Given this list of marker genes SMARCC1, MYEF2, METTL2A, DNLZ, NFKB2, MDN1, ROR2, CTBS, SOX17, SETD4, ATG9B, OSR2, NHP2, C18orf54, HSPBAP1 (HSPB1 associated protein 1), TRIM9, PMF1, LRP8, HIRA (histone cell cycle regulator), YBX3, NSUN5, NME1, DHX58, SNRPG, SNX24, SFSWAP, MYC, DDX49, NELFA, RAD23A, PDXK, NOL8, VARS1, STOML1 (NCBI Gene Id 9399), CCDC86, ASCL2, GAR1, ZBTB21, QTRT2, EPHB2, ATRIP, RPL31, FZD6, MVK, NFS1, OGFOD1, THOP1, PTHLH, MUS81, PMM1, RANGRF, LRMDA, TP53RK, GTSE1, D2HGDH, SMPD4, RGS12, GNPNAT1, SRGAP2, BOD1L1, HAGHL, ZNF800, LMNB2 (NCBI Gene Id 84823), KAT2A, RNASEH2C, FARSB, CDK4, DENND6B, SLC1A3, RAI14, ARX, ERCC1, DDAH1 (NCBI Gene Id 23576), SHPRH, SIDT1, ANKRD39, ERCC4, FBL, TRDN, NEUROG3, TFPT, MUTYH, RCC2, RASSF4, PCBP4, ACER2, GIPC1, POLE, QTRT1, FADS2, EMC8, BMP7, TGIF2, SLC1A4, FADS3, MCM3, TRMT61A, TFIP11, SLCO3A1, RABEP2, NTMT1, SNRPF, KNOP1, PABPC4, LANCL2, METTL1, TXNRD2, SLC35B2, ZBED3, GINS2, RNASEH2A, CDC42BPA, AAAS, RPS6KA6, ATMIN, METTL13, NBEAL2, RPS13, CABCOCO1, MYBBP1A, DRG2, MRPL38, LFNG, NASP, PHGDH, IFFO2, GTPBP3, NCEH1, CCDC163, ZSWIM3, HOMER1, ALKBH2, ZNF213, GET1, TELO2, SOX4, DPH2, YAE1, SIGMAR1, TIMELESS, ZMYND19, DUS3L, PPP1R14B, BIVM, ZBTB48, GRWD1, YJU2, CINP, TP53, GEMIN5, TMEM141, MCM7, DYNC2I2, TUBB2A, HOXA9, TTC27, TMPO, NOP56, POLR1A, SEMA3B, GTPBP6, PTOV1, SAPCD2, OGG1, FHOD1, WDR62, TMEM186, TRIB1, BCL11B, EXOSC1, BID, CENPP, BCL11A, AAR2, SMYD5, NRF1, DTYMK, GORASP1 (NCBI Gene Id 64689), RRP9, NOLC1, HES6, MBD3, GAS8, BUB1B, PRSS41, CREBBP, CITED1, POFUT1, VARS2, USP20, VEZT, C17orf49, SIVA1, WDR54, SHMT1, LHPP, SKA1, POMT1, AQR, TK1, CCT4, RNF157, SHMT2, ZNF444, CAD, SRD5A3, MFSD13A, TNFRSF12A, MAP4K4 (mitogen-activated protein kinase kinase kinase kinase 4), ADAT1, PPAN, SLC29A2, SRM, LDB1 (LIM domain binding 1), TXNRD3, ARHGEF12, AXIN2, MED22, MAPK7, RAD54L, ZFP2, SYTL1, CCT7, WDR4, TRMT9B, here is a description of the gene set: from publication Sansom OJ, Meniel VS, Muncan V, Phesse TJ, Wilkins JA, Reed KR, Vass JK, Athineos D, Clevers H, Clarke AR (PMID 17377531) Human Gene Set: SANSOM_APC_TARGETS_REQUIRE_MYC studied in species Mus musculus The APC gene encodes the adenomatous polyposis coli tumour suppressor protein, germline mutation of which characterizes familial adenomatous polyposis (FAP), an autosomal intestinal cancer syndrome. Inactivation of APC is also recognized as the key early event in the development of sporadic colorectal cancers, and its loss results in constitutive activity of the beta-catenin-Tcf4 transcription complex. The proto-oncogene c-MYC has been identified as a target of the Wnt pathway in colorectal cancer cells in vitro, in normal crypts in vivo and in intestinal epithelial cells acutely transformed on in vivo deletion of the APC gene; however, the significance of this is unclear. Therefore, to elucidate the role Myc has in the intestine after Apc loss, we have simultaneously deleted both Apc and Myc in the adult murine small intestine. Here we show that loss of Myc rescued the phenotypes of perturbed differentiation, migration, proliferation and apoptosis, which occur on deletion of Apc. Remarkably, this rescue occurred in the presence of high levels of nuclear beta-catenin. Array analysis revealed that Myc is required for the majority of Wnt target gene activation following Apc loss. These data establish Myc as the critical mediator of the early stages of neoplasia following Apc loss. Genes up-regulated after Cre-lox knockout of APC in the small intestine that require functional MYC.